Given this list of marker genes Dclk1, Ldb2, Lrfn5, Pthlh, Pgr, Tnfrsf13c, Ermp1, Usp29, Toe1, Rbms3, Dek, Sltm, Smndc1, Pds5b, Cbx2, Rwdd2a, Fkbp14, Zfp809, Zbtb11, Caap1, Thrb, Mbnl1 (muscleblind like splicing regulator 1), Dnajc1, Alkbh5, Cnot6, Myct1, Tpo, Mef2c, Strbp, Cfl1, Jam2, Zranb2, Fbxo24, Pla2g4b, Mrps17, Lgalsl, Poc5, Ankrd17, Hecw2, Kctd6, Ttc14, Rhou, Snx12, Smg1 (SMG1 nonsense mediated mRNA decay associated PI3K related kinase), Mllt11, L2hgdh, Guf1, Serinc3, Esd, Treml4, Fkbp10, here is a description of the gene set: Mouse Gene Set: MIR_6365 studied in species Mus musculus from publication Chen Y, Wang X (PMID 31504780) Genes predicted to be targets of miRBase v22 microRNA mmu_miR_6365 in miRDB v6.0 with MirTarget v4 prediction scores > 80 (high confidence targets).